The following is a description of a gene set: The movement of cilia of epithelial cells of the Left Right Organizer (LRO), also referred to as the node in mouse or the Kupffer's vesicle in zebrafish, resulting in the leftward fluid flow across the LRO and generation or transport of a signal which determines asymmetry in an organism's body plan with respect to the left and right halves. Human Gene Set: GOBP_EPITHELIAL_CILIUM_MOVEMENT_INVOLVED_IN_DETERMINATION_OF_LEFT_RIGHT_ASYMMETRY studied in species Homo sapiens, and this is the list of marker genes: CFAP45, CCDC40, DNAAF1, CCDC103, ODAD4, CCDC39, OFD1, ODAD3, DNAH11, RFX3, DNAAF11, CFAP53, NPHP3